Given this list of marker genes ALK, here is a description of the gene set: part of: Drug resistance of ALK mutants Reactome Pathway: NVP-TAE684-resistant ALK mutants species: Homo sapiens NVP TAE684 is a second generation tyrosine kinase inhibitor with activity against some ALK mutants, including some that show resistance to crizotinib. This pathway describes ALK mutants that show resistance to inhibition by NVP TAE684.